Given this list of marker genes GTF2F2P2, CFAP251, LTN1, RPL7P3, ACVR1, ACSM6, RBM42, PSG6, LINC02463, TUG1, SLC30A6P1, ADAM32, ENSG00000221060, PCNX2, MPHOSPH6, CADM1, FAM43A, NPM1P31, RERE-AS1, BCL7A, GALNT10, HLCS, AMBN, MIR4505, ABHD17C, KCTD15, LINC02395, NET1, NAA20, HIBCH, BAZ2B, ENSG00000261924, RPL5P30, TRIM15, ALG1, PLSCR3, LRRTM4, ACBD6, ALDH3B1, BAK1, CMC1, THAP11 (THAP domain containing 11), SNORD81, KRTAP4-1, CFAP410, ENSG00000253397, GARS1-DT, QRFPR, SPINK1, STK40, CTBP1-DT, SLC14A2, ENSG00000259961, STPG3-AS1, FHAD1, ESYT1, LINC01348, KAZN, GRN, NLRP1, MRPS18C, ZNF177, MYO18A, SKIDA1, NPM1P39, NPM1P7, CIPC, RNU6-338P, RPL5P5, LMNA, MT-ND6, PTOV1, TRGVA, WDR1, R3HDM2, NEUROD4, ZBTB7C, RSRC2, SP110, RNU7-136P, ARNT, POLDIP3, TINAG, GBGT1, STK26, PSG4, ACER3, NARS1, TMEM150C, PAOX, GARIN2, CARMIL2, SPATS2L, SUZ12 (SUZ12 polycomb repressive complex 2 subunit), GORASP2, CD46P1, MIR3973, RGS3, SLC7A7, MIR5586, CBX1P4, ARHGEF16, TRIM29, MYBPC2, ZNF793, AFTPH-DT, CHST8, RCAN1, OR9A1P, RBBP6, ACVR2B, FKBP3, CBX1, LINC00111, ZNF821, NAE1, B3GALNT2, EIF5A2 (NCBI Gene Id 57114), MIR4434, GSDMA, LINC01723, SLC25A12, HSPD1P11, OR52K2, CR1L, TBC1D1, GET1, RN7SL735P, TXNRD2, CORO1C, SYT14, DND1 (DND microRNA-mediated repression inhibitor 1), POLR3B, NT5CP1, YPEL4, NOL8 (nucleolar protein 8), CAPZBP1, FANCM, NUP133-DT, ABLIM2, KLRK1, SF3B2, SULT6B1, CDK6-AS1, ENSG00000260288, ZNF8-DT, NUAK1 (NUAK family kinase 1), GUSBP18, ODAD4, PPARA, BUD23, NLGN3, NXPH1, IRGC (immunity related GTPase cinema), BNIP3L, LINC02794, RPL27P6, TMEM255A, TNFRSF9, CANX, FA2H, ERCC6L, HMGN2P9, IFI6, SERPINB12, LLPHP3 (LLPH pseudogene 3), MBTPS1, MCCC2, RNF217, EGFR, SEC31B, RIBC1, MEGF11, RNU6-181P, SGK1, RPS15AP18, RERE, PTPRO, TMEM207 (transmembrane protein 207), SORBS1, POC1B, NELFB, TM9SF3, ZNF250, ANKUB1, C2orf80, MEIS1 (NCBI Gene Id 4211), PDZD2, DNAJC18, CHIC2, APOBEC3H, RNU6-799P, SELENOF, DTD1, RPS4XP6, PSMC1P12, NPM1P37, PKM, LINC00649, ARID1A, NDUFA3P2, ZBTB20, DNAJC30, POC1B-AS1, SPTAN1, RPL12P22, GAL3ST3, SMG8, RAP1BP3, TMEFF2, SCRN1, AP2B1, SCMH1, POLR2M, MPDU1-AS1, UBQLN1-AS1, DYNC2I1, ENSG00000202517, TPM3, IPO4, FAM237A (NCBI Gene Id 200726), FARP2, RPS25, RN7SL204P, GHITM, ZNF8-ERVK3-1, SDAD1P1, MT-TT, SNORA62, ATP8A2, DLG4, RPL21P23, LRRC20, FEZ2, CBX1P3, TRABD2A, HNRNPD, NAA35, BPI, PPP2R2A, CSRNP3, LRRC49, PGBD4, EFCAB6, TACC2 (transforming acidic coiled-coil containing protein 2), LINC02396 (long intergenic non-protein coding RNA 2396), LINC01838, TMEM140, CREB5, TRIT1, IFFO1, EFTUD2, MRPS24, METAP1D, MYOM2, VAMP3, VAMP8, CFAP57, ENSG00000240207, RGS22, ADGRE1, CD300LG, PDE7B-AS1, GRB10, MAEA, NPM1P24, RPS3AP55, MRPL58, WNT5B, FCRL1, ENSG00000272668, TRAF2, CITED2, CHMP3-AS1, CFL1P3, ARF1, MEIOC, UBE3D, ZNF833P, CTTNBP2NL, NCR2, WDR81, ACLY, ATP5PF, MPRIP-AS1, EPN2 (NCBI Gene Id 22905), CTBP1, CERK, MPC2, C19orf12, STC1, H2AC8, PRPF19, ITSN1, DNMT1, RPSAP64, RUVBL1, ESR2, ELF2, FAXDC2, CRYM, CLUL1, NTAN1P1, TOE1, DHRS1 (NCBI Gene Id 115817), GARNL3, RPS15AP30, TMC6, NDUFV1-DT, PTDSS2, CIBAR1, CDKL1, CNTN1, PPP1R12C, LNPK, GNG4, ENSG00000258926, GFRA1, ZNF267, MTND5P11, ENSG00000215156, THUMPD1, PHLDB1, GOT2P6, RPL38, TUBB4AP1, AGK, HOXA-AS2, ZNF224, IGFN1, GEM, PHB1P12, PDPN, SELENOP, SMAD9, RPL4P2, LPP, NAPSB, MT-TE, UBA2, MX2, GAS2L3, SLC2A6, RPS6P26 (ribosomal protein S6 pseudogene 26), HELQ, SNX11, PACS1, PDZD7, DIAPH1-AS1, SOX2-OT, RTN4R, SMARCD2, MTF2 (NCBI Gene Id 22823), EMC7, UPP2, RN7SL209P, TRAPPC4, SLC24A1, MIR22HG, SEL1L3, LINC02772, CALCOCO1, BEST4, MIR6124, KAT8, SMC1A, UBQLN1, GLYR1, SREBF1, ITGA4, EPHB4, MAST2, NR2F1-AS1, TCF7L2, PIGUP1, BCAR3-AS1, S100A11, NDUFA12, IFT46, MCM2, SMOX, NDUFV1 (NADH:ubiquinone oxidoreductase core subunit V1), NGRNP2, ZNF8, STMP1, C6orf132, SLC25A37, RTF2, SPRY4-AS1, SECTM1, GAMTP2, MESDP1, ZNF211, ATP6V0E1P2, DCAF6, MICAL3, ERC1, EWSAT1, MUTYH, L3MBTL1, LINC01891, SEPTIN11, CLTCL1, LGALS1, SLC16A13, NIT2, HSD11B1-AS1, PRELID1P6, AFF1, KIAA0753 (NCBI Gene Id 9851), EDNRA, ARL6, SUZ12P1, MYG1, OAS2, PPBPP2, GOLGA2P5, DNAJC19 (NCBI Gene Id 131118), CCDC74A, IST1, SNX27, PHF5AP7, FAM106A, MTCO3P12, RPL27, EPB41L2, FAM110C, SPAST, TM7SF2, CXCR6, MYOM3, RHPN2, TMEM14A, CTSB, CDC6, DIAPH1, CASK, APAF1, PLK1, TLN1, ZC3H10, ZNF226, TTC23L, GINS4, OSBP2, LINC02642, LINC01972, EPHA7, EXOC4, SLC30A3, GAP43, ZNF887P, CHRNA7, ENSG00000267024, TMEM236 (transmembrane protein 236), ATE1, RPL10A, MOV10L1, C1QBP, FRAS1, RPS2P24 (ribosomal protein S2 pseudogene 24), BCOR, PFN1P11, STOML2, CYYR1-AS1, GNB1, NAPSA, STRN4, B3GNTL1, CYB5R3, CHD3, DNAJB6P7, GALNT4, ADGRV1, EBNA1BP2, TEFM, AP3D1, ANAPC5, TINAG-AS1, ANXA2R, HOPX, RNF186-AS1, MYO1C, PTH1R, CD44-AS1, PCGF1, ASB13, ENTPD6, CENPT, ZNF773 (NCBI Gene Id 374928), SIX4, ZNF75A, SNCAIP, LINC02294, RNU6-248P, ITGA6-AS1, CBX7, LARP6, SBF2-AS1, ADAP2, NPY6R, ZNF432 (zinc finger protein 432), here is a description of the gene set: Human Gene Set: ZNF490_TARGET_GENES species: Homo sapiens Genes containing one or more binding sites for (ZNF490) in their promoter regions (TSS -1000,+100 bp) as identified by GTRD version 20.06 ChIP-seq harmonization. from publication Yevshin I, Sharipov R, Kolmykov S, Kondrakhin Y, Kolpakov F (PMID 30445619)